Given this list of marker genes BRCA1, FANCD2 (NCBI Gene Id 2177), FANCE, FANCC, PCNA, RBBP8, FANCG, FANCF, ATR, EWSR1, CCNE1, ATM, XRCC5, RAD51, UBE2D3, NPM1, TOPBP1, MRE11, UBE2L3, CDK2, BARD1, FANCL, FANCA (FA complementation group A), XRCC6, CSTF1, RAD50, PRKDC, NBN, TP53, here is a description of the gene set: studied in species Homo sapiens from publication Schaefer CF, Anthony K, Krupa S, Buchoff J, Day M, Hannay T, Buetow KH (PMID 18832364) Human Gene Set: PID_BARD1_PATHWAY BARD1 signaling events